Given this list of marker genes Polg2, Pold3, Pole, Polg, Pold4, Pole4, Crcp (calcitonin gene-related peptide-receptor component protein), Pole2, Dna2, Mad2l2, Pola2, Pold2, Prim1, Rev3l, Pole3, Pola1, Prim2 (DNA primase, p58 subunit), Pold1, here is a description of the gene set: species: Mus musculus A protein complex that possesses DNA polymerase activity and is involved in template directed synthesis of DNA. Mouse Gene Set: GOCC_DNA_POLYMERASE_COMPLEX